The following is a description of a gene set: After translocation into the nucleus, AKT can phosphorylate a number of targets there such as CREB, forkhead transcription factors, SRK and NUR77. species: Homo sapiens Reactome Pathway: AKT phosphorylates targets in the nucleus part of: PIP3 activates AKT signaling, and this is the list of marker genes: NR4A1, AKT1, FOXO3, FOXO1, FOXO6, RPS6KB2 (NCBI Gene Id 9017), AKT2, AKT3, FOXO4, CREB1